The following is a description of a gene set: Multipotential naïve CD4+ T cells differentiate into distinct lineages including T helper 1 (Th1), Th2, Th17, and inducible T regulatory (iTreg) cells. The remarkable diversity of CD4+ T cells begs the question whether the observed changes reflect terminal differentiation with heritable epigenetic modifications or plasticity in T cell responses. We generated genome-wide histone H3 lysine 4 (H3K4) and lysine 27 (H3K27) trimethylation maps in naïve, Th1, Th2, Th17, iTreg, and natural (n)Treg cells. We found that although modifications of signature cytokine genes (Ifng, Il4, and Il17) partially conform to the expectation of lineage commitment, critical transcription factors such as Tbx21 exhibit a broad spectrum of epigenetic states, consistent with our demonstration of T-bet and IFN-gamma induction in nTreg cells. Our data suggest an epigenetic mechanism underlying the specificity and plasticity of effector and regulatory T cells and also provide a framework for understanding complexity of CD4+ T helper cell differentiation. Genes up-regulated in comparison of Th2 cells versus natural regulatory T cell (Treg). Human Gene Set: GSE14308_TH2_VS_NATURAL_TREG_UP from publication Wei G, Wei L, Zhu J, Zang C, Hu-Li J, Yao Z, Cui K, Kanno Y, Roh TY, Watford WT, Schones DE, Peng W, Sun HW, Paul WE, O'Shea JJ, Zhao K (PMID 19144320) studied in species Homo sapiens, and this is the list of marker genes: NAPSA, CHD7, SLC7A5, GPM6B, CARD19, ERCC6L, HUS1, RAD51D, PRKACA, COASY, GTF2F2, ATAD5, MCEE, UBL5, PLPP4, FAM216A, UBE2J2, TRIM72, UBXN2A, GPRIN3, COX7A1, WASHC4, WRAP73, DRG1, DEPP1, GAB3, PHYHIPL, PLEKHF1, STK11, BCLAF1, CEP135, CDV3 (CDV3 homolog), STT3B, SARS1, RAB24, RMC1, YPEL4, ECI2, PLBD2, EXOSC4, ERG28, WDR53, TRAPPC5, NUPR1, OTUB2, CIT, HTR2B, NOP56, KYAT3, GMPR2, CHCHD2, SLC30A9, NDUFB10, FOXG1, MAGI2, ERLEC1, POC5, KIN, ZNF800, HAGH, CEP72, YBX3, SRR (NCBI Gene Id 63826), SNRPN, GIN1 (NCBI Gene Id 54826), CEP250, FXN, PPIA, BTC, SRRD, AHRR, TMEM199, SNX25, MRPL19, SPSB2, SPRY2, PKD2, PASK, RTL8B, NDN, AGBL3 (AGBL carboxypeptidase 3), ATP6V0D1, FBXO34, POLE, VTI1A, NUP93, UPF3A, WDR74, MINDY1, CISD3, PCSK4, CCDC86, G6PD, RAP1B, CFAP20, ANXA7, SKAP1, IL3RA, TMCO1, BORCS7, NOBOX, JMJD6, LGALS7, RALA, NOB1, TMEM86A, STXBP5L, THAP1, RIT1, TULP1, OTOS, RPL14, MZT2B, SMC5, BBS12, MFAP5, APOL2, SPRYD4, GET4, ZBTB7A, PIGA, ECSCR, RGR, HAGHL, WBP4, STX7, FOXM1, TMEM143, FSTL3, EPS8, TMEM41B, MDM1, NHP2, MFSD12, DKKL1, OXSM, YDJC, TIMM9, ABCB10, GALNS, HS6ST1, TMEM30A-DT, BYSL, BAG2, POGLUT3, MYO15B, TMX3, GRIN2D, KRT80, MN1, MDFIC (NCBI Gene Id 29969), GCAT, WEE1, TOLLIP, MTLN, ZHX3, SOCS1, DENND11, BST2, ST3GAL4, MTX2, NFKBIZ, CLTC, PRKCSH, PNO1, BET1, TRIM3, SAP30BP, SOX6, ORMDL2, EXOC3L4, SOX9, UXS1, PCBP4, DPP7, NDE1, USP5, ALDH1A3, INHBA, COPS5, MIS18A, VIT, CCDC88A, SMCO3, RBKS, B9D2, DAB2, ARFGAP3, VPS39, BPGM, P2RY10, VCPKMT, NUP155, FANCD2, KARS1, BORCS5, GJC2, BLTP2, TIMM17B